Given this list of marker genes GLIPR1L1, TTC29, MMP8, ANKRD34A, CCDC175, CHAT, PLSCR4, HOXC8, ADAMTS15 (ADAM metallopeptidase with thrombospondin type 1 motif 15), FAM81B, KRTAP8-1, COL1A1, PDE6A, PDIA5, ASB11, EMG1, SSTR4, DPPA2, UCHL3, SH3BGRL, WDFY3, SBSPON, EEF1AKMT1, TAL1, EYA4, C1orf174, KCNT2, SGSM1, C2orf88, SLC22A13, WWC2, PTCHD4, C1QL3, ANGPTL4 (angiopoietin like 4), ANGPTL1, CENPS, PPIH, HYKK, HTRA3, LRP3, KCTD4 (potassium channel tetramerization domain containing 4), PTMS, KRTAP17-1, THYN1, PIK3R6, TOB2, COLEC10, GREB1L, TIMP3, MARVELD3, KLK7, LPAR1, TMA16, DOC2A, XRCC2, HOXA3, TTL, PCDHB1, HPF1, TPMT, TMEM229A, SNCAIP, DENR, COLCA1, RIC3, RNF17, RTP3, ZSCAN29, CXCL6, ADGRE5, PRAMEF2, FAM204A, PLXNB2, GATA2, ROBO4, PCDHB13, DRGX, USP29, RYR3, MRPL40, ZNF704, FLACC1 (flagellum associated containing coiled-coil domains 1), LRRTM3, TIMM10, QTRT2, ADRA2B, PCLAF, ARL4D, TAGLN2, EXTL3, NEUROD1 (NCBI Gene Id 7853), SATB2, SNF8, BACE1, DBN1, SCIN, TMEM238, DLGAP1, VSX2, CYP26B1, CMSS1, PTX3, CDK18, PSMA7, CHST1, GABRG1, CCL1, ZMYND12, TNFSF11, UGT2B4 (NCBI Gene Id 7363), PCSK5, COL11A1, PTPN11, CYP4F2, GCSH, EML6, TIMM9, NAA20, ORMDL2, IRF8, RBFOX2, RAB5IF, CETN3, KLHL33, CFAP45, CNR1, NHP2, MRPL50, SAXO1, MIR99AHG (mir-99a-let-7c cluster host gene), LIX1, PMS1, LSM7, YBX3, CCDC141, BRD3OS, GTPBP8, PSMA8, CDH1, DKK2 (dickkopf WNT signaling pathway inhibitor 2), COL14A1 (collagen type XIV alpha 1 chain), PDE7B, LARP6, EGR3, KLRK1, PRPF19, CACNA2D3, IL1RAPL1, SMARCA1, CACNG3 (calcium voltage-gated channel auxiliary subunit gamma 3), RBM24, CTHRC1, BEST2, DLX2, SSX5, MRPL12, ENTREP2, GUCY1A1, MAOB, ADGRB3 (NCBI Gene Id 9664), MARCHF10, HAS1, TRIR, GSX2, ERH, THBS2, CHCT1, CTTNBP2, FERMT2, L3HYPDH, DPT, SPARC, ASPN, PGBD5, CHST8, CD160, ABCA6, MAPK4 (mitogen-activated protein kinase 4), SPRY2, CENPM, GPRC6A (G protein-coupled receptor class C group 6 member A), TIAM2, NHERF4, CP, UGT2B15, STOX2, ANKRD45, FSTL1, LARP7, ITGA9, PIGT, PIWIL1, PHF24, SLC22A23 (NCBI Gene Id 63027), INAVA, PHF5A, BEX4, TM4SF1, SLC22A9, here is a description of the gene set: Genes up-regulated in monocytes: untreated versus M. tuberculosis 19 kDa lipopeptide (24h). In innate immune responses, activation of Toll-like receptors (TLRs) triggers direct antimicrobial activity against intracellular bacteria, which in murine, but not human, monocytes and macrophages is mediated principally by nitric oxide. We report here that TLR activation of human macrophages up-regulated expression of the vitamin D receptor and the vitamin D-1-hydroxylase genes, leading to induction of the antimicrobial peptide cathelicidin and killing of intracellular Mycobacterium tuberculosis. We also observed that sera from African-American individuals, known to have increased susceptibility to tuberculosis, had low 25-hydroxyvitamin D and were inefficient in supporting cathelicidin messenger RNA induction. These data support a link between TLRs and vitamin D-mediated innate immunity and suggest that differences in ability of human populations to produce vitamin D may contribute to susceptibility to microbial infection. from publication Liu PT, Stenger S, Li H, Wenzel L, Tan BH, Krutzik SR, Ochoa MT, Schauber J, Wu K, Meinken C, Kamen DL, Wagner M, Bals R, Steinmeyer A, Zügel U, Gallo RL, Eisenberg D, Hewison M, Hollis BW, Adams JS, Bloom BR, Modlin RL (PMID 16497887) Human Gene Set: GSE8921_UNSTIM_0H_VS_TLR1_2_STIM_MONOCYTE_24H_UP species: Homo sapiens